The following is a description of a gene set: Human Gene Set: GSE21033_CTRL_VS_POLYIC_STIM_DC_12H_DN Genes down-regulated in bone marrow-derived dendritic cellstreated by poly(IC): 0h versus 12h. from publication Olex AL, Hiltbold EM, Leng X, Fetrow JS (PMID 20682054) BACKGROUND: Dendritic cells (DC) play a central role in primary immune responses and become potent stimulators of the adaptive immune response after undergoing the critical process of maturation. Understanding the dynamics of DC maturation would provide key insights into this important process. Time course microarray experiments can provide unique insights into DC maturation dynamics. Replicate experiments are necessary to address the issues of experimental and biological variability. Statistical methods and averaging are often used to identify significant signals. Here a novel strategy for filtering of replicate time course microarray data, which identifies consistent signals between the replicates, is presented and applied to a DC time course microarray experiment. RESULTS: The temporal dynamics of DC maturation were studied by stimulating DC with poly(I:C) and following gene expression at 5 time points from 1 to 24 hours. The novel filtering strategy uses standard statistical and fold change techniques, along with the consistency of replicate temporal profiles, to identify those differentially expressed genes that were consistent in two biological replicate experiments. To address the issue of cluster reproducibility a consensus clustering method, which identifies clusters of genes whose expression varies consistently between replicates, was also developed and applied. Analysis of the resulting clusters revealed many known and novel characteristics of DC maturation, such as the up-regulation of specific immune response pathways. Intriguingly, more genes were down-regulated than up-regulated. Results identify a more comprehensive program of down-regulation, including many genes involved in protein synthesis, metabolism, and housekeeping needed for maintenance of cellular integrity and metabolism. CONCLUSIONS: The new filtering strategy emphasizes the importance of consistent and reproducible results when analyzing microarray data and utilizes consistency between replicate experiments as a criterion in both feature selection and clustering, without averaging or otherwise combining replicate data. Observation of a significant down-regulation program during DC maturation indicates that DC are preparing for cell death and provides a path to better understand the process. This new filtering strategy can be adapted for use in analyzing other large-scale time course data sets with replicates. studied in species Homo sapiens, and this is the list of marker genes: DNAJB12, CCDC198, MFAP3L, AKR7A2, CCDC68, KIF25-AS1, SP3, TSPAN3, H1-2, SLC25A11, SERPIND1, MSRA, SFT2D2, CHD1, MAP2K1 (mitogen-activated protein kinase kinase 1), KLHL21, GCLM, H2BC9, FRAT1, CLDN14, DLG4, RUVBL1, RBPJ, CEP135, PHF3 (NCBI Gene Id 23469), UBL4A (NCBI Gene Id 8266), IFRD1, RRAGA, ANTKMT (adenine nucleotide translocase lysine methyltransferase, NCBI Gene Id 82377), TMCC1, MOCS3, ADCY8, KPNA1, PLD1 (phospholipase D1), PGK1, SS18L2, SOS1, GNG10, VPS16, SLC35B1, CHRM5, F9, WSCD1, SAGE1, GPD1L, LRRC42, SRPRB, HBD, ADORA2B, CRTAM, ASNS, ATRN, RTP4, ESPL1, CRELD2, TMX4, RHOQ, MTPAP, RAB4A, OXSM, IL1RAP, USP10, LINC01278, SPP1, TM2D3, INTS9, PAIP1, STBD1, NKAPD1, ERI3, GNAT3, DOCK10, PPIH, AKAP10, FAM13B, HEATR1, MXI1, CEP70, RUNDC3B, PRORP, LAPTM4A, ME1, TERF1, ACVR1, PPP3R1, GSPT2, TTC33, LDHA, RND3, HIC1, SUMO4, CYP11B2, DDIT3, SUPV3L1, ZFYVE16, GMDS, EFR3A, SFTPA2, SOCS5, CHAF1B, UTP11, SERGEF, GSTM3, TMEM209, TRIM16, QRICH1, G3BP1, ZSCAN31, CITED2, DNAJC3, NRG1, ZNF518A, PNRC2, BRIX1, CHST15, OPN3, CEP164, FGF21, PDPR, AMFR (NCBI Gene Id 267), PTGS2, MLH1, CTSC (cathepsin C), NUP54, CCDC51, CAAP1, ZNF646, SYNJ2, TMEM39A, RALA (NCBI Gene Id 5898), ATP6V1C1, OXLD1 (NCBI Gene Id 339229), FLAD1, GMPS, ABI2, TMEM248, HEXIM1, KIT, STRAP, GALC, SOS2, ASF1A, IRX4 (iroquois homeobox 4), ABL1, CLSTN1, PABPC4, MT1X, CSF2, TUBGCP3, TRAPPC14, TMED3, ZNF302, MRPS10, MED24, PSMB5 (proteasome 20S subunit beta 5), MTRR, MRPL11, KEAP1, TWNK, ZFP69B, TP53, C1RL, RCBTB2, YTHDC1, WDR43, HDAC2, MYH1, TGIF1, TSG101, ANG, SGCA, RNF113A, MCTP1, FAF2, CAMSAP2, PTTG3P, VAMP2, SEMA4D, NCAPG2, LRIG1, TAPBPL, PELI2, H2BC21, SEL1L, ATF7IP, PRCC, MSC, AKIP1, TJAP1 (tight junction associated protein 1), ING3, MKLN1, TBC1D8, MAF, PRMT5, GID8, UBE2W, RCN1, BABAM2, STX5, WDR25